The following is a description of a gene set: species: Homo sapiens Human Gene Set: GGGYGTGNY_UNKNOWN Genes having at least one occurrence of the highly conserved motif M31 GGGYGTGNY in the regions spanning 4 kb centered on their transcription starting sites. The motif does not match any known transcription factor binding site. from publication Xie X, Lu J, Kulbokas EJ, Golub TR, Mootha V, Lindblad-Toh K, Lander ES, Kellis M (PMID 15735639) Comprehensive identification of all functional elements encoded in the human genome is a fundamental need in biomedical research. Here, we present a comparative analysis of the human, mouse, rat and dog genomes to create a systematic catalogue of common regulatory motifs in promoters and 3' untranslated regions (3' UTRs). The promoter analysis yields 174 candidate motifs, including most previously known transcription-factor binding sites and 105 new motifs. The 3'-UTR analysis yields 106 motifs likely to be involved in post-transcriptional regulation. Nearly one-half are associated with microRNAs (miRNAs), leading to the discovery of many new miRNA genes and their likely target genes. Our results suggest that previous estimates of the number of human miRNA genes were low, and that miRNAs regulate at least 20% of human genes. The overall results provide a systematic view of gene regulation in the human, which will be refined as additional mammalian genomes become available., and this is the list of marker genes: FLNA, ZFP82, IQGAP1, CCN5, MGST3 (microsomal glutathione S-transferase 3), NAV2, E4F1 (NCBI Gene Id 1877), TCF7L1, KCNN4, RNF111, PDZD11, GCC2-AS1, PKLR, ZNF775, RBM3, MGAT4B, NDRG1, BTD, ELAVL3, RYBP, H2BC5, HMGN3, HCK, SGTB, GDA, BCLAF1, ANKRD55, CRISPLD2, CDK6, PLCB3, SLC4A2, TFE3, PDLIM5, MEF2D, SIK3, STMN1, CORO7 (NCBI Gene Id 79585), FGD1, TMX4, POF1B, KLF5, FAM76A, ZFY, CLDN7, FGFRL1 (NCBI Gene Id 54966), DDIT4, AGO1, FOSB, SHOX2, DHX35, PIGU, PRX, PLP2, RHOQ, CHD4, WDR25, HPCA, GRIA1, MOV10, HLX, SLC2A4, TIE1, ATP1A3, MIRLET7BHG, TMEM106C, SCT, ATF7, CSK, LCTL, MPP2 (NCBI Gene Id 4355), CALM2, CAMTA2, CHL1, CTTNBP2NL, MTNAP1, CDKN2B, FXYD3, OVOL2, MIEF2, SLC25A28, ACBD3, CBX8 (chromobox 8), TAB2, ATN1, DEPDC1B, FES, OGT, ARMCX6, CLIC4, CCNI, AP4M1, SOST, IST1, ARPC1A, ADSS2 (NCBI Gene Id 159), FRY, PHF20, SAR1A, NFKB2, RAB6B, CEP15, PIH1D1, BCL2L13, LSM12, AP3D1, FKBP1A, ADH1C, ITPKC, ADH1B, CDH13, SERPINB5 (NCBI Gene Id 5268), TUBA1A, DSG1, CALHM3, SPAG17, PARP12, SLC7A8, PMP22, NKX6-3, PAFAH1B3, FKBP2 (NCBI Gene Id 2286), TRIB2, S1PR1, PALM, PSD, SCN8A, CDC42SE1, RARG, DLL4, LMX1A, PRR16, MBOAT7, UBQLN4, ARHGAP36, OSER1, GTF3C6, PIK3AP1 (phosphoinositide-3-kinase adaptor protein 1), CELF3, HSPA5, KAT5, YWHAZ, RHBDL3, NUAK2, SH3RF1, PAX9, SOX12, MLLT11, CRLF1, ABR, KCNA6, NCKAP5, RALGPS2, CRK, OSM, PPP1R12A, PRR7, TMEM229B, PRUNE2, ATL1, SPAG5, OSR1, ARMCX1, YWHAH, CATSPER2, DNAJB1, NADK, WNT3, DNAJC14, VASH1 (NCBI Gene Id 22846), TFF2, ADGRF3, SLC25A12, FGFR2, COL11A2, CAP1, CTF1, SYNE1, B4GALT6, ADH1A, CHD5, ADCK5, VIM, HYCC1, PTK7, LMX1B, TMEM184B, SLC7A1, NOVA2, DBP, NUP93, NKX2-3, VSIG1, CAV1, PLA2G15, FAM117A (family with sequence similarity 117 member A), CAMKK1, OVOL1, MORF4L2, EIF1, BEND7, KCNK13, DALRD3, ZFAND3, MIR22HG, MSANTD2, CLEC11A, IGSF1, PRRG1, YBX2, MAGEE2, RAB8A, CAPRIN1, DPYSL5, UBL3, STAG2, FOXJ2, CCDC88A (NCBI Gene Id 731560), ADCY10, STRADB, SARM1, LUC7L2, UBA6, TRIM47, HOXB4, KLF13, SPOCK2, ALDH6A1, SYNGR4, MDK, PLXNC1, CD44 (CD44 molecule (IN blood group)), CDK16, NRG2, ASAP2, EPB41L4B, RAP2C, PPP1R14D (protein phosphatase 1 regulatory inhibitor subunit 14D), TFAP4, POU5F1, PDZD2, ATAT1, NELL2, PCBP4, KCNE5, FHL1, DTX1, MAP4K3, SMARCB1, PCDH9, SUV39H1, SRGAP2, CYP2W1, CAPNS2, NCOA2, ELF4, LAMC2, ZBTB47, SELENOS, RCOR2, PAK4, NCAPH2 (non-SMC condensin II complex subunit H2), LRRC59, SUCO, ST20-AS1, CHRNB1, TRPV2, ILVBL, LRRN2, BET1, DYNLL1, THOC6, ARL4A (NCBI Gene Id 10124), TRAK2, RTKN, BLOC1S3, SLITRK1, PLS1, WDR48, STX1A, EPB41L3 (erythrocyte membrane protein band 4.1 like 3), GPC4, KRT33B, WDR20, ULK2, POU2AF1, PER1, GPC2, KLHL35, MFN2, ADAM17, RNF170, CAST, RAMP2, GRK5, ACTB, TRAPPC14, RDH11, AKT1, CACNG4, DIABLO (diablo IAP-binding mitochondrial protein), PTOV1, RBM11, DAAM1, HS3ST3A1, ATP1A1, DCTN2, ZBTB32, NYAP1, RBM14, STYK1, CNNM2, TMEM88, JADE2 (jade family PHD finger 2), DENND6A, PRMT1, TRERF1, KRTAP13-2, LMF2, ITSN1, FAF1, MBLAC2, JAG1, VAMP2, KCNK7, PDE11A, COQ8B, FAM13B, TSEN34, ARFGEF1, PPRC1, NCAM1, GMIP, USPL1, GNG11 (NCBI Gene Id 2791), NR3C1, FAM20B, BOC, FAM161B, INTS4, HSD17B10, KIF5A, NFYA, HCFC1R1, LAMP2, NCOA3, ERGIC3, MTFR1, HMGCS1, EML2, KCND1, AHNAK, ANKRD40CL, APLP2, ZNG1B, NOSTRIN, REEP6, DCP2, C16orf87, PAK3, ABHD2, ZBTB45, PHF1, HOOK3, SPINK7, CRMP1, RGS3 (regulator of G protein signaling 3), PDIA5, BCS1L, RAB8B, ZBTB37, MMP1, ERO1B, TMED1, PTK2B, COL13A1, GIGYF2, RNF19B, SFN, TOMM40L, RTN1, PERP, CDK17, PRRC2A, TNFSF13, MAGEL2, DDAH2, SGO2, KCNAB2, DPYSL2, DYNC2I2 (NCBI Gene Id 89891), TUSC3 (NCBI Gene Id 7991), ATXN7L1, CSRNP1, HAS1, CAMLG, FEV, BHLHE40, PI15, MORC3, CCDC107, AVPI1, SEMA6A, MCUB, PDLIM7, GABRA3, MALL, TXNRD1, NLRP6, SRFBP1, LAMTOR2, SEZ6L, NXPH4, TULP2, RTN4R, ZEB1, ZBTB41, APBB1, CANX, SPPL3, RAB39A, CHD2, KRTAP13-1, XK, PODN, DENND2D, COL1A2, PACS1, STAG3, ADISSP, BDNF, COL9A1, NAB2, GNAI2, SENP2 (SUMO specific peptidase 2), IGDCC4, TRAPPC6A, PDIK1L, PPP3R1, C1orf198, RORA, DACH2, WDR81, KMT2E, PHOX2B, AP2B1, FLNB, C6orf136, USP15, FGFBP1, IFRD1, ANXA2, DPAGT1, STMN4, EFNA3, CDHR5, H1-4, TMOD3, NAPB, USP14, ZNF335, ZFX, KCNH2, ADCY8, GSE1, SEC11A, LGALS1, EEFSEC, MARCHF8, TGFB1I1, NR2F6, WSB1, CELF6, ADGRF1, OARD1, SRPX, ZNG1A, PSMD1, GRM3, LIX1, HIF3A, VAT1, MTMR3, GRK6, KRT25, RAB10, GPX4, WEE1, XPO1, MOSPD3, UCHL3, TYRO3, FAR1, HSD17B8, EXOC6, ZMYM3, ADRB1, DBI, KCNH4, CACNA1B, GDPD3, ITGB4, MITF, CALCOCO1, AMOT, ABI1, UTP14C, ATP7B (ATPase copper transporting beta), PHF21A, SEC14L3, ZC2HC1C, WNT5A, DGKZ, RAB30, TENT5B, COQ6, RPS6KA5, ARMCX2, SLC25A21, NTRK2, SENP3, JUP, CELF1, PLEC, NUCB1, UCHL1, RASL10B, TTLL1, PRKCG, TENT5A, KCNK3, RGS14 (regulator of G protein signaling 14), PPFIA2, KLK3 (kallikrein related peptidase 3), LENG8, OLFM2, NFATC1, SMYD5, MAP4K5, IMP3, EPHB2, RTL3, CCDC90B, SH2D3C, CKMT1B, XPO7, VCF1, SCML2 (Scm polycomb group protein like 2), COL6A3, KRT10, CD22, ATL2, CRYZL1, RALBP1, MTPN, FUT1, HNRNPR, KIF4A, PRKAG1, TMEM50A, PLXNA3, WDR1, WASF2, SLC35B1, RIN1, RARB, GAP43, EDIL3, ZNRD2, SPEG, FAM20A, SCN4A, LGI4, RABEP2, THRA, FARP1, ERLIN2, MYCL, SH3KBP1 (SH3 domain containing kinase binding protein 1), IKZF4, ITGA3, RAPGEFL1, SOWAHA, STX5, CPT1A, PPP2CA, TSPAN6, ATP10D, NAPA, FBXL2, SEMA3B, ACBD5, GNMT, ATP2C1, BMP6, RAB11B, MCU, H6PD, LAMB3, CLPB, ABI3BP, HNRNPL, VTN, BCL11A, HNRNPD, IPPK, GOLGA5, APOD, GPR22, DOLPP1, KPNB1, IGFBP3, ZNF367, CLEC18C, CLDN3, NLN, WDR44, ZMYM5, BMPR2, RNF152, EFS, ZNF414, JAKMIP1, TP53INP2, MRPL48, LGALS3, PXN, CALHM2, RGS8, GSK3A, SNX2, MYADM, EXOC7, STXBP2, RPS6KA3, CDK5, SLC43A1, IL7, CNTFR (NCBI Gene Id 1271), LPAR4, UBR4 (ubiquitin protein ligase E3 component n-recognin 4), MAGOHB, CPNE6, NR4A3, INKA1, KDELR2, ALDH16A1, SAP130, POLR3G, ETV4, KCNC1 (NCBI Gene Id 3746), GCHFR, SLC38A2, DCX, KPNA4 (karyopherin subunit alpha 4), LTB4R, SLC16A10, ELL, RBBP7, MIEN1, ZBTB9, MAP1B, SMOC1, DOCK9, SLC31A2, ATOSB, APOLD1, KCNH8 (NCBI Gene Id 131096), NEK8, ABCB6, EFNB1, STAT6, MAGED2, MAPK6, ATP5MC2, CDH5, SMAD5, CEP68, MIR137HG, FAM110A, VGLL4, TMEM143, SLCO4A1 (NCBI Gene Id 51737), VTI1B, PLPPR2, MCM7, NDUFAF3